Given this list of marker genes CNIH3, LMAN1, TGFA, TMED2, TMED10, SERPINA1, F5, PREB, SEC24B, CNIH1, MCFD2, AREG (NCBI Gene Id 727738), CNIH2, SEC24C, FOLR1, MIA2, CTSZ, CTSC, CD59, LMAN2, SEC24A, SEC24D, GRIA1, LMAN2L, COL7A1, STX5, MIA3, SEC22B, F8, GOSR2, SEC23A, LMAN1L, SAR1B, here is a description of the gene set: Human Gene Set: REACTOME_CARGO_CONCENTRATION_IN_THE_ER Cargo concentration in the ER studied in species Homo sapiens